The following is a description of a gene set: The process in which the anatomical structures of the brain are generated and organized. The brain is one of the two components of the central nervous system and is the center of thought and emotion. It is responsible for the coordination and control of bodily activities and the interpretation of information from the senses (sight, hearing, smell, etc.). Mouse Gene Set: GOBP_BRAIN_MORPHOGENESIS studied in species Mus musculus, and this is the list of marker genes: Gak, Afdn, Psen2, Psen1 (presenilin 1), Tuba1a, Otx1, Smo, Pafah1b1, Fgf8, Duox2, Vps51, Ctnna2, Hesx1, Gsx2, Foxo3, Otx2, Nf1, Sos1, Slc6a4, Gba1, Cdh2, Nfix, Hhex, Pten, Bbs2, Mir124a-1, Uchl5, Sox2, Pax2, Shank3, Akt3, Spef2, Magee2, Prop1, Fbxw11, Wnt5a, Fancd2, Gdf7, Ift88, Fancc, Bbs1, Mkks, Bbs4 (Bardet-Biedl syndrome 4), Slc4a10, Pcnt, Zfp335, Emx1